Given this list of marker genes Socs3, Egfr (NCBI Gene Id 13649), Hras, Pxn, Khdrbs1, Erbb4, Cbl, Crk, Dok1, Ubb, Erbb2, Rps27a, Rasa1, Bcar1, Btc, Gpnmb, Khdrbs2, Hif1a, Ptpn1, Arap1, Ccnd1, Ccne1, Cdk4, Cdkn1b, Nrg3 (NCBI Gene Id 18183), Khdrbs3, here is a description of the gene set: studied in species Mus musculus part of: Signaling by Non-Receptor Tyrosine Kinases This event has been computationally inferred from an event that has been demonstrated in another species.<p>The inference is based on the homology mapping from PANTHER. Briefly, reactions for which all involved PhysicalEntities (in input, output and catalyst) have a mapped orthologue/paralogue (for complexes at least 75% of components must have a mapping) are inferred to the other species. electronically inferred by orthology from the curated human pathway Reactome Pathway: Signaling by PTK6